The following is a description of a gene set: species: Homo sapiens Human Gene Set: REACTOME_GPCR_LIGAND_BINDING GPCR ligand binding, and this is the list of marker genes: KISS1R, HTR1E, GAL, NTS (NCBI Gene Id 96646), GNRH2 (NCBI Gene Id 2797), P2RY10, IHH, BDKRB2, TAS2R60, PRLH, CXCL6, CXCL5, ADGRE1, NMBR, HTR6, PF4, GALR3, RXFP1, NMU, HCAR3, HTR2A, RAMP3, TRHR, SSTR3, WNT2 (NCBI Gene Id 7472), NMUR2 (neuromedin U receptor 2), CNR1, GPR37, CXCL16, CCR5, PROKR1, LPAR2, GNGT2, CCL17, VIPR2, OPN5, TAS2R9 (taste 2 receptor member 9), GPRC6A, MCHR2, ADRA2B (adrenoceptor alpha 2B), GPR65, TACR3, FZD5, CORT, ACKR2, WNT3A, GPR31, P2RY13, TAS2R43, ADRA2C, WNT7B, CCL3, TAS2R46, GPHA2, GLP1R, PTAFR, EDN2, GNG5, SMO, LPAR5, F2RL1, GPBAR1, FFAR1, CX3CL1, FZD7, CGA, HTR2B, TAS2R3, APP, F2RL2, AGTR1, UTS2, PTH, TAS1R2, S1PR3, TAS1R3, CD55, DRD5, PTGER3, ECE1, NPY4R, CHRM1, CHRM2, BRS3, HCAR1, HTR5A, GCGR, TAS2R4, ADRB1, FFAR3, CCL16, CCL3L3, MC2R, AVP, PPY, CCL4, SSTR2, C5AR2, PTH2R, CCL23, DRD3, CXCL1, CCK, MLN, TSHB, NLN (neurolysin), LPAR3, XCL2, CCR8, ADCYAP1, F2, GABBR2, FZD10, FSHR, S1PR1, ADRA1A, ADRB3, FZD6 (frizzled class receptor 6), CCL7, AGTR2, CCL2, S1PR5, WNT11, KNG1, PLPPR5, PMCH, GRM6, OPN1SW, EDN3, TAS2R14, MLNR, HTR1F, GNB5, TAC1, AGT, PTCH1, DRD2, SSTR1, CCL21 (C-C motif chemokine ligand 21), TAS2R42, CXCL11, FZD9, TAAR8, HCRTR1, FPR1, ADRA2A, PTGER2, LTB4R, ADORA1, DHH, OXER1, WNT2B, GNGT1, OXGR1, TAS2R8, GPR132, GALR1, QRFP (pyroglutamylated RFamide peptide), C3AR1, ADGRE2, GNRH1, ADGRE3, GNAS, GCG, CXCR6, RRH, SST, CXCL3, CCR9, WNT5A, NPFF, SAA1, NTSR1 (neurotensin receptor 1), NPY2R, KISS1, P2RY12, PPBP, NTSR2, C3, SCT, GHRH, OPN1LW (NCBI Gene Id 8261), PROKR2, HRH1, PLPPR1, CRHBP, GRM5, GPER1, FFAR2, CALCA, WNT9B (Wnt family member 9B), CHRM3, GPR143, HEBP1, TAS2R38, GRM1, WNT9A, OXTR, S1PR2, GNG4, ANXA1, TAS2R20, TAAR9, SCTR (NCBI Gene Id 6344), P2RY6, TAS2R13, ACKR3, SHH, PROK2, PTGER4, GHRHR, PTGIR, P2RY4, HCRTR2, UTS2B, GPR17, GPR18, CXCL10, EDNRB, NMS, AVPR1A, MCHR1, GRPR, GRM2, CX3CR1, CHRM4, FZD2 (frizzled class receptor 2), SUCNR1, OPN4, F2RL3, ECE2, ADRB2, CMKLR1, TAAR1, ADRA1D, CCR10, KEL, PSAP, QRFPR, CXCR5, MTNR1B, CCL25, CNR2, GIP, CXCL12, CXCR3 (NCBI Gene Id 2833), XK, HTR7, APLNR, CCL28, OPRK1, FPR2, FZD3, CCRL2, GNB2, GABBR1, PTH1R, EDNRA, HTR1A, OPN1MW (NCBI Gene Id 2652), NPB, GNG7, UCN, CCR1, TAS2R19, GNRHR, TAAR6, S1PR4, RXFP2, GNG11, CCR2, CALCRL, GNG8, LTB4R2, GLP2R, GPR35, ADORA2B, MTNR1A, LHB, RGR, TAS2R40, WNT8A, NPY5R, TSHR, RLN2, XCL1, OPN3, CRHR2, CRH, GNG10, CCL13 (C-C motif chemokine ligand 13), PLPPR2, VIP, FZD1, CALCB, UCN2, MC3R, HTR4, PTGDR, TACR2, CHRM5, CASR, HRH3, TAS2R31, WNT4, TAS2R10, WNT10A, FZD8, PROK1, NMUR1, ADORA2A, LPAR1, NPS, GNB3, ACKR4, NPBWR2, HCRT (NCBI Gene Id 3060), LHCGR, SSTR5, CCL27, FSHB, PTH2, GPR68, CCL22, INSL3, RXFP3, TAS2R50, HRH2, NPFFR1, EDN1, AVPR2, CCKBR, CALCR, VIPR1, RLN3, WNT1, GALR2, CCL19, TAAR5, GHSR, MC5R, WNT7A, CCKAR, CRHR1, AVPR1B, CYSLTR2, LPAR4, PDYN, PTGDR2, MC4R, GRP (gastrin releasing peptide), TAC3 (NCBI Gene Id 6866), GNG13, BDKRB1, PRLHR, WNT10B, DRD1, UCN3, POMC, GPR4, GPHB5, GRM4, CCR6, ADGRE5, OXT, PTGER1, PLPPR4 (phospholipid phosphatase related 4), SSTR4, GHRL, ADM2, NPW, NPY1R, CCL20, CCL1, GRM7, PNOC, CXCR1, CCL5, WNT16, CXCL8, LPAR6, WNT3, RHO, GRM8, NMB, TAS2R1, HTR1D, HCAR2, ADCYAP1R1, PENK (proenkephalin), TBXA2R, NPFFR2, APLN, P2RY14, HRH4, RXFP4, NPBWR1, P2RY11, CYSLTR1, CXCL9, GNB4, ACKR1 (NCBI Gene Id 2532), GPR39, PTGFR, TACR1, RAMP1, ADRA1B, PLPPR3, FFAR4, TRH, NPY, P2RY1, IAPP, CXCL13, TAS2R39, C5, DRD4, FPR3, RAMP2, CXCL2, OPRL1, TAS2R30, TAS2R5, CCR4, WNT6, XCR1, GPR183, CCL11, TAAR2, GNG3, CXCR2, CCR7, FZD4, HTR1B, MC1R, TAS2R16 (taste 2 receptor member 16), PTCH2, HTR2C, NPSR1, GPR55 (NCBI Gene Id 9290), ADORA3, PYY, WNT8B, P2RY2, F2R, C5AR1, UTS2R, OPRM1, GRM3 (NCBI Gene Id 2913, glutamate metabotropic receptor 3), INSL5, GNG12, CCR3, GNG2, PTHLH, TAS2R41, GIPR, GPR37L1, TAS2R7, TAS1R1, CXCR4, GNB1, OPRD1, ADM